Given this list of marker genes NODAL, INHBA, TBX6, ITGA3, HOXA11, TRIM15, KDM6B, GJA1, SFRP2, FOXF1, TAL1, KLF4, ITGA8, ITGB3, MESP1, TAF10, MIR200C, WNT3A, ITGB1, ITGB4, BMP4, MIR145, HMGA2, EYA1, FGFR2, FOXC2, PAX2 (NCBI Gene Id 5076), DKK1, MIR150, EYA2, SMAD1, ITGA2, BMPR1A, FGFR1, SIX2, here is a description of the gene set: species: Homo sapiens Human Gene Set: GOBP_MESODERMAL_CELL_DIFFERENTIATION The process in which a relatively unspecialized cell acquires the specialized features of a mesoderm cell.